Given this list of marker genes 1a, rep, here is a description of the gene set: species: Homo sapiens Reactome Pathway: Maturation of replicase proteins_9684325 part of: Translation of Replicase and Assembly of the Replication Transcription Complex Production of polyprotein fragments (so called replicase proteins) involves the repeated autocleavage of the polyprotein, liberating the two endopeptidases that finally cleave all fragments efficiently. Only nsp3 and nsp4 are post-translationally modified, they are glycosylated